The following is a description of a gene set: Human Gene Set: REACTOME_RUNX3_REGULATES_YAP1_MEDIATED_TRANSCRIPTION species: Homo sapiens RUNX3 regulates YAP1-mediated transcription, and this is the list of marker genes: TEAD2, RUNX3, WWTR1, YAP1, TEAD3, CCN2, TEAD4 (NCBI Gene Id 7004), TEAD1